The following is a description of a gene set: studied in species Homo sapiens Human Gene Set: GOBP_POSITIVE_REGULATION_OF_CANONICAL_NF_KAPPAB_SIGNAL_TRANSDUCTION Any process that activates or increases the frequency, rate or extent of a canonical NF-kappaB signaling cascade., and this is the list of marker genes: NUP62, NOD1, TRIM8, LTB, IRAK1, LTF, TAB2, TNFSF11, TIFA, TFRC, DAB2IP, SHISA5, CCL21, EDAR, PLEKHG5, RHOA, ANKRD17, DDX1, TLR3, TLR7, TAB3, DDX21, IKBKB, VAPA, MAVS, SHARPIN, ABL1, CLEC6A, ECT2, CD40, TLR2, CASP10, EDA, HMOX1, GPR89A, HUWE1, BST2, CCL19, IL1R1, MUL1, TRAF6, CX3CL1, WLS, BIRC2, EDNRB, PLCG2, CX3CR1, CD4, UBE2V1, PIM2, UBD, TBK1, MIB2, IKBKG, LIMS1, F2RL1, IRAK1BP1, BCL10, ALPK1, DHX15, PELI1, MAP3K7, MALT1 (MALT1 paracaspase), LGALS9 (galectin 9), MTDH, PLK2, CHUK, PRKN, TRIM32, TMEM101, PRKCB, DDRGK1, PARP1, S100A13 (S100 calcium binding protein A13), VEGFA, LPAR1, TIFAB, IKBKE, UBE2N, ZDHHC13, IRAK3, TRIM62 (tripartite motif containing 62), CLEC7A, CASP8, TRAF2, BTK, HLA-DRB1, CTH, TLR4, ATP2C1, TRIM25, CAV1 (NCBI Gene Id 857), PYCARD, TNFSF14, BRD4, NOD2, TNFSF10, FLNA, TIRAP, SLCO3A1, CCDC22, MYD88, TFG, RNF31, RHOC, CFLAR, BIRC3, IRAK4, INSR, FBXW11, CANT1, FADD, TGFB1, TRADD, TRIM13, PPM1A, PRKD1, NEK6, SLC20A1, GPRC5B, TICAM1, CD36, SLC44A2, LGALS1, INS, IRAK2, NR2C2, NAMPT, LAMTOR5, LTA, TNF, TRIM52, IL1A, LITAF, GOLT1B, HTR2B, CC2D1A, FLOT1, INAVA, ZDHHC17, TLR9, TRAF3IP2, TICAM2, PSMA6, EDNRA, REL, TMEM9B, CLEC4D, LRRC19, PRL, F2R, AKAP13, FKBP1A, TNFRSF1A, IRF3, TNIP2, CARD9, RBX1, SLC35B2, STAT3, MAP3K3, JMJD8, ADIPOQ, LURAP1L (NCBI Gene Id 286343), TRAF5, FLOT2, EDN1, CD40LG (CD40 ligand), FASLG, CXXC5, MAS1, MID2, S100A4, NDFIP2, RBCK1, UNC5CL, RIPK1 (receptor interacting serine/threonine kinase 1), DHX36, CD74, TRIM22, TLR6, NFAT5, CUL1, TERF2IP, TNFSF15, PELI2, GJA1, ECM1, UBE2I (NCBI Gene Id 7329), PINK1, PPP5C, TRIM38, EDA2R, TNFRSF19, NDFIP1, XIAP (X-linked inhibitor of apoptosis), CCR7, C18orf32, TRIM5, CARD11, TSPAN6 (tetraspanin 6, NCBI Gene Id 7105), LTBR (lymphotoxin beta receptor), GAPDH, LURAP1, PRKCE, TNFRSF10B, CASP1, RIPK2, RELA, IL1B, MIER1, ILK, TLR8, TMEM106A, TMED4, ZC3HAV1, CARD14, S100B, S100A12, AJUBA, ROR1, TNFRSF11A, APOL3, CARD10, IFIT5, SECTM1, CARD16